Given this list of marker genes LYN, TNIP1, CD14, IFITM3, SEC14L1, IFITM1, CD8A, here is a description of the gene set: from publication Weinberger B, Haks MC, de Paus RA, Ottenhoff THM, Bauer T, Grubeck-Loebenstein B (PMID 29868000) Genes positively correlated with high anti-HBs concentration at week 30 in blood in young/old adults (20-40)/(60-84) (primary vaccination) after exposure to Twinrix, time point 1D. Comment: Correlation between pre-immunization expression levels of single genes (log2-transformed) and anti-HBs concentrations (log10-transformed) at week 30 post-primary vaccination Many current vaccines are less immunogenic and less effective in elderly compared to younger adults due to age-related changes of the immune system. Most vaccines utilized in the elderly contain antigens, which the target population has had previous contact with due to previous vaccination or infection. Therefore, most studies investigating vaccine-induced immune responses in the elderly do not analyze responses to neo-antigens but rather booster responses. However, age-related differences in the immune response could differentially affect primary versus recall responses. We therefore investigated the impact of age on primary and recall antibody responses following hepatitis B vaccination in young and older adults. Focused gene expression profiling was performed before and 1 day after the vaccination in order to identify gene signatures predicting antibody responses. Young (20-40 years; <i>n</i> = 24) and elderly ( > 60 years; <i>n</i> = 17) healthy volunteers received either a primary series (no prior vaccination) or a single booster shot (documented primary vaccination more than 10 years ago). Antibody titers were determined at days 0, 7, and 28, as well as 6 months after the vaccination. After primary vaccination, antibody responses were lower and delayed in the elderly compared to young adults. Non-responders after the three-dose primary series were only observed in the elderly group. Maximum antibody concentrations after booster vaccination were similar in both age groups. Focused gene expression profiling identified 29 transcripts that correlated with age at baseline and clustered in a network centered around type I interferons and pro-inflammatory cytokines. In addition, smaller 8- and 6-gene signatures were identified at baseline that associated with vaccine responsiveness during primary and booster vaccination, respectively. When evaluating the kinetic changes in gene expression profiles before and after primary vaccination, a 33-gene signature, dominated by IFN-signaling, pro-inflammatory cytokines, inflammasome components, and immune cell subset markers, was uncovered that was associated with vaccine responsiveness. By contrast, no such transcripts were identified during booster vaccination. Our results document that primary differs from booster vaccination in old age, in regard to antibody responses as well as at the level of gene signatures. Clinical: www.clinicaltrialsregister.eu, this trial was registered at the EU Clinical Trial Register (EU-CTR) with the EUDRACT-Nr. 2013-002589-38. species: Homo sapiens Human Gene Set: WEINBERGER_BLOOD_TWINRIX_AGE_20_40_AND_60_84YO_CORRELATED_WITH_HIGH_ANTI_HBS_CONC_AT_WEEK_30_PRIMARY_VACC_1DY_POSITIVE